The following is a description of a gene set: Covalent attachment of a glycosyl residue to a lipid molecule. Mouse Gene Set: GOBP_LIPID_GLYCOSYLATION studied in species Mus musculus, and this is the list of marker genes: Slc35c1 (solute carrier family 35, member C1), Glt6d1, St3gal4, Gba1, B3galt1, B4galnt1, Abo, Ggta1, B4galnt2, Gbgt1, Gba2, A3galt2, St3gal2, 4930402F06Rik, 4930568D16Rik